Given this list of marker genes Atraid, Mn1, Grem1, Plxnb1, Nell1, Axin2, Ahr, Nf2, Smad3, Tnn, Bcl2, Sfrp1, Eif2ak2, here is a description of the gene set: Mouse Gene Set: GOBP_NEGATIVE_REGULATION_OF_OSTEOBLAST_PROLIFERATION studied in species Mus musculus Any process that stops, prevents or reduces the rate or extent of osteoblast proliferation.